The following is a description of a gene set: Increased anterosuperior prominence of the area between the bottom of the incisura and the inner margin of the antihelix. Human Gene Set: HP_PROMINENT_ANTITRAGUS Prominent antitragus studied in species Homo sapiens, and this is the list of marker genes: RAB3GAP2, KAT6A, CHST3, B3GAT3, PGM2L1, PIGK